Given this list of marker genes CGB3, FSHB, INHBE, LHB, INHBC, POMC, INHA, PCSK1, TSHB, INHBB, CGA, INHBA, here is a description of the gene set: Peptide hormones are peptides that are secreted directly into the blood stream (endocrine hormones). They are synthesized as precursors that require proteolytic processing (not discussed here) to generate the biologically active peptides that mediate neurotransmission and hormonal action. Glycoprotein hormones (those which include carbohydrate side-chains) and the processing of corticotropin are annotated here. part of: Peptide hormone metabolism Reactome Pathway: Peptide hormone biosynthesis species: Homo sapiens